The following is a description of a gene set: Human Gene Set: KEGG_MEDICUS_REFERENCE_PURINE_SALVAGE_PATHWAY_ADENINE_TO_AMP Pathway Definition from KEGG: AMP -- NT >> (PNP,LACC1) -> Adenine -- APRT -> AMP species: Homo sapiens Purine salvage pathway, adenine to AMP. Pathway ID: N01418. Pathway type: Reference. Pathway class: nt06027 Purine salvage pathway., and this is the list of marker genes: NT5C1A, PNP, LACC1 (NCBI Gene Id 144811), NT5M, NT5C1B-RDH14, APRT, NT5C1B, NT5DC4, NT5C, NT5C2, NT5E